Given this list of marker genes SERPINE2, CBLN1, OPHN1, PROX1, WNT7A, NRXN1 (NCBI Gene Id 9378), KNDC1, KIF14, GRID2, here is a description of the gene set: Human Gene Set: GOBP_CEREBELLAR_GRANULAR_LAYER_MORPHOGENESIS studied in species Homo sapiens The process in which the anatomical structure of the cerebellar granular layer is generated and organized. The granular layer is the innermost layer of the cerebellar cortex. This layer contains densely packed small neurons, mostly granule cells. Some Golgi cells are found at the outer border. Granule neurons send parallel fibers to the upper molecular layer, where they synapse with Purkinje cell dendrites. Mossy fibers from the pontine nuclei in the white matter synapse with granule cell axons, Golgi cell axons and unipolar brush interneuron axons at cerebellar glomeruli in the granule cell layer.